Given this list of marker genes AKT1, AKT2, FOXO1, AKT3, here is a description of the gene set: part of: Regulation of gene expression in beta cells The unphosphorylated form of FOXO1A shuttles between the nucleus and cytoplasm, maintaining a substantial concentration of this protein in the nucleoplasm, where it functions as a transcription factor. Phosphorylation of the protein, catalyzed by activated AKT, causes its exclusion from the nucleus. Reactome Pathway: AKT-mediated inactivation of FOXO1A studied in species Homo sapiens